The following is a description of a gene set: TRAF6-mediated induction of TAK1 complex within TLR4 complex studied in species Mus musculus Mouse Gene Set: REACTOME_TRAF6_MEDIATED_INDUCTION_OF_TAK1_COMPLEX_WITHIN_TLR4_COMPLEX, and this is the list of marker genes: Cd14, Ubc, Ticam1, Sarm1, Ticam2, Irak2, Map3k7, Tab1, Ly96, Rps27a, Tab3, Tlr4, Tab2, Uba52rt, Uba52, Traf6, Ubb